Given this list of marker genes ABAT, ECT2, TREM2, CTDSPL2, FGA, TTN, CEP290, CAPN10, CHRM1, GPLD1, PDX1, IRS2, NADK, NR1H2, TM9SF4, TLR2, GPR27, PRR5L (proline rich 5 like), VPS28 (NCBI Gene Id 51160), OR51E2, SIRT6, IL1B, SMO, APBB3, TARDBP, EMD, GSK3B, SYTL4, AKAP5, PPIA, UCN3, UBR5, PIK3R1, IPO5, PRKCE, BMP6, SOX4, PPARD, MYRIP, ZPR1, ADAM8, BCAP31 (B cell receptor associated protein 31), OAZ3, IFNG, YWHAE, BSG, VPS35, HDAC3, PRKAR1A, PRP4K, PRKN, PDCD10, C1QTNF3, TRPM5, BLK, RBP4, ORAI1, PSEN1, TENM1, ASPH (aspartate beta-hydroxylase), PTPN23, ACSL4, TGFB2, TRH, EFCAB7, ABCG1, MDM2, TNF, CD33, MAVS, XPO4, OXCT1, TMED10, APBB1, GLUD1, PPM1A, RAN, F2, FUT10, VAMP2, APP, ZIC1, GOLPH3L, CRYZL2P-SEC16B, ADORA2A, PCK2, PLCB1, CDH1, CD81, IGF1, MYOM1, F2RL1, RAC1, GIP, ISL1, NNAT, KIF20B, CASR, ATP2C1, SLC2A2, SLC30A8, RAPGEF3 (Rap guanine nucleotide exchange factor 3), ARF6, PRKACA, ACSL3, VEGFC, SLC35D3, GNA11, CDK1, GLI3, CHP2, NMU, PSMD9, TRPA1, RIPOR1, TCF7L2, PLK3, PFKM, C2CD2L, GPER1, ABCC8, ZC3H12A, TUNAR, HYAL2, RBM22, WLS, PPP3CB, IER3IP1, PLA2G6, GAS6, C1QTNF12, DYNLL1 (NCBI Gene Id 8655), NKX6-1, BAIAP3, ERGIC3, GCG, CHP1, TMEM132A, ANO1, TMEM30A, CHRM3, TMEM30B, HIF1A, FFAR1, PARD6A, DNM1L, STX4, FGG, AACS, ACHE, RAPGEF4, TPR, NR1H4, PCM1, TM7SF3, SEC24A, ZDHHC2 (NCBI Gene Id 51201), BAD, KCNN4, OAZ1, PRKCD, PRKCB, ADAM9, SEC16B, TRIM28, CNST, CLN3, PIK3R2, SFN, JAK2, RPH3AL, IL1A, TRPM4, MPC2, SIRT3, NR0B2, FRMD4A, COMMD1, SORL1, BAG3, ANP32B, FFAR2, CD2AP, IL13, RUFY3, XBP1, INS (insulin), FLNA, CRH, ANKRD1, GCK, VSNL1, ANG, PGRMC1, APOE, EDEM1, FUT11 (fucosyltransferase 11), DOC2B, P2RX7, HCLS1 (NCBI Gene Id 3059), SHH, TSG101, SMAD3, TGFB1, MYO18A, MCU, B3GAT3, NLGN2, PCNT, CFTR, PPID, ADCY8, OSBP, DMAP1 (NCBI Gene Id 55929), MIR199B, HCAR2 (hydroxycarboxylic acid receptor 2), TLR4, CAMK1, SERP1, GIPR, MLXIPL, EXPH5, PRKCA, TGFB3, ZFAND1, JUP, ANXA13, PHPT1, RAB29, RACK1, MYH10, GPRC6A, PRKD1, HLA-DRB1, LRRC8A, RFX6, HSP90AA1, CD38, EDEM2, MAPK14, ARHGEF5, LEP, ICE1, ATP13A2, CEP131, GPR68, FGB, UNC13B, OAZ2, PLA2G1B, ITPR1, SLC51B, TMEM97, F2RL2, EP300 (NCBI Gene Id 2033), GHRL, SYBU, PPARG, PFKFB2, GOLPH3, here is a description of the gene set: Human Gene Set: GOBP_POSITIVE_REGULATION_OF_PROTEIN_TRANSPORT species: Homo sapiens Any process that activates or increases the frequency, rate or extent of the directed movement of a protein into, out of or within a cell, or between cells, by means of some agent such as a transporter or pore.